The following is a description of a gene set: Any process that modulates the frequency, rate or extent of intestinal lipid absorption. species: Homo sapiens Human Gene Set: GOBP_REGULATION_OF_INTESTINAL_LIPID_ABSORPTION, and this is the list of marker genes: ABCG8, PRAP1, CYP8B1, APOA1, CLDN2, CLDN15, LPCAT3, APOA2 (NCBI Gene Id 336), ABCG5, APOA4, ENPP7, LEP